The following is a description of a gene set: The E2F family of transcription factors regulate the transition from the G1 to the S phase in the cell cycle. E2F activity is regulated by members of the retinoblastoma protein (pRb) family, resulting in the tight control of the expression of E2F-responsive genes. Phosphorylation of pRb by cyclin D:CDK complexes releases pRb from E2F, inducing E2F-targeted genes such as cyclin E.<p>E2F1 binds to E2F binding sites on the genome activating the synthesis of the target proteins. For annotation purposes, the reactions regulated by E2F1 are grouped under this pathway and information about the target genes alone are displayed for annotation purposes.<br>Cellular targets for activation by E2F1 include thymidylate synthase (TYMS), Rir2 (RRM2), Dihydrofolate reductase (DHFR), Cdc2 (CDK1), Cyclin A1 (CCNA1), CDC6, CDT1, CDC45, Cyclin E (CCNE1), Emi1 (FBXO5), and ORC1. The activation of TK1 (Dnk1) and CDC25A by E2F1 is conserved in Drosophila.<br>RRM2 protein is involved in dNTP level regulation and activation of this enzyme results in higher levels of dNTPs in anticipation of S phase. E2F activation of RRM2 has been shown also in Drosophila by Duronio and O'Farrell (1994). E2F1 activation of CDC45 is shown in mouse cells by using human E2F1 construct. Cyclin E is also transcriptionally regulated by E2F1. Cyclin E protein plays important role in the transition of G1 in S phase by associating with CDK2. E2F1-mediated activation of PCNA has been demonstrated in Drosophila and in some human cells by using recombinant adenovirus constructs. E2F1-mediated activation of the DNA polymerase alpha subunit p180 (POLA1) has been demonstrated in some human cells. It has also been demonstrated in Drosophila by Ohtani and Nevins (1994). It has been observed in Drosophila that E2F1 induced expression of Orc1 stimulates ORC1 6 complex formation and binding to the origin of replication. ORC1 6 recruit CDC6 and CDT1 that are required to recruit the MCM2 7 replication helicases. E2F1 regulation incorporates a feedback mechanism wherein Geminin (GMNN) can inhibit MCM2 7 recruitment of ORC1 6 complex by interacting with CDC6/CDT1. The activation of CDC25A and TK1 (Dnk1) by E2F1 has been inferred from similar events in Drosophila (Duronio RJ and O'Farrell 1994; Reis and Edgar 2004). E2F1 activates string (CDC25) that in turn activates the complex of Cyclin B and CDK1. A similar phenomenon has been observed in mouse NIH 3T3 cells and in Rat1 cells. part of: G1/S Transition Reactome Pathway: G1/S-Specific Transcription studied in species Homo sapiens, and this is the list of marker genes: POLA1, LIN54, ORC1, PCNA, CDC45, LIN52, CDK1, TFDP1, E2F1, E2F4, CDC6, E2F6, E2F5, RBBP4, TK1, RBL2, RRM2, CDC25A, HDAC1, CCNA1, RBL1, DHFR, LIN37, LIN9, TFDP2, TYMS (thymidylate synthetase), CCNE1, FBXO5, CDT1